Given this list of marker genes GNB2, WDR26, KIF15, AFF2, NEXMIF, YME1L1, RAI1, ZSWIM6, DPAGT1, TAF4, here is a description of the gene set: Stereotypic whole-body movements Abnormal movements of the whole body. species: Homo sapiens Human Gene Set: HP_STEREOTYPIC_WHOLE_BODY_MOVEMENTS